Given this list of marker genes TDG, POLB, MBD4, MPG, MUTYH, APEX1, SMUG1, UNG, here is a description of the gene set: Base excision and strand cleavage by monofunctional glycosylase. Pathway ID: N01433. Pathway type: Reference. Pathway class: nt06504 Base excision repair. Human Gene Set: KEGG_MEDICUS_REFERENCE_BASE_EXCISION_AND_STRAND_CLEAVAGE_BY_MONOFUNCTIONAL_GLYCOSYLASE studied in species Homo sapiens Pathway Definition from KEGG: glycosylase -> APEX == POLB